The following is a description of a gene set: studied in species Homo sapiens The process where the cap structure, composed of a 7- methylguanosine (m7G) group and associated cap-binding proteins, located at the 5' end of an mRNA molecule, which serves as a molecular tag that marks the spot where the 40S ribosomal subunit, is recruited and will then scan in a 5' to 3' direction until an AUG codon is encountered in an appropriate sequence context to initiate mRNA translation. Human Gene Set: GOBP_CAP_DEPENDENT_TRANSLATIONAL_INITIATION, and this is the list of marker genes: NCBP2, SLBP, EIF4G1, NCBP1, EIF3D, PKP1, MIF4GD, AKT2, NCK1